The following is a description of a gene set: The process in which the anatomical structures of the embryonic heart tube are generated and organized. The embryonic heart tube is an epithelial tube that will give rise to the mature heart. species: Homo sapiens Human Gene Set: GOBP_EMBRYONIC_HEART_TUBE_MORPHOGENESIS, and this is the list of marker genes: TEAD2, DNAAF1, FGF8, WNT5A, STIL, SHH, TBX3, ARL13B, MKKS, VANGL2, TMED2, HAND1, MEGF8, HAND2, PSEN1, NDRG4, MIB1, CLUAP1, BBS5, HES1, RNF207, MESP1, OVOL2, ENG, DVL1, SOX18, NOTCH2, NODAL, WNT3A (NCBI Gene Id 89780), CITED2, NPHP3, CCDC39, FOXN4, ACVR1, YAP1, SUFU, ZIC3, MEF2C, CCDC103, IHH, NKX2-5, NOTO, BBS7, TBX2, FOXH1, DLL1, IFT52 (intraflagellar transport 52), DVL2, AHI1, TBX20 (NCBI Gene Id 57057), PKD2, C2CD3, GATA4 (NCBI Gene Id 2626), FOLR1, TGFBR2, IFT57, LBX1, APLNR (NCBI Gene Id 187), ASB2, CCDC40, RYR2, SRF (serum response factor), NOTCH1, SETDB2, SOX17, SMAD3, MICAL2, IFT172, HIF1A, SMO